Given this list of marker genes TGFB3, EPAS1, ELOB, FH, TGFA, TGFB2, CUL2, EGLN3, EGLN1, VEGFA, SLC2A1, HIF1A, RBX1, EGLN2, COL21A1, SFPQ, PDGFB, TFEB, ARNT, CDKN1A, VHL, ARNT2, CREBBP, TFE3, ELOC, PRCC (NCBI Gene Id 5546), CADM2, DIAPH1, CTSK, SETD2, TGFB1, DVL2, EP300, BIRC7, here is a description of the gene set: studied in species Homo sapiens Type 2 papillary renal cell carcinoma Human Gene Set: WP_TYPE_2_PAPILLARY_RENAL_CELL_CARCINOMA